The following is a description of a gene set: studied in species Homo sapiens Any process that modulates the frequency, rate, or extent of heterotypic cell-cell adhesion. Human Gene Set: GOBP_REGULATION_OF_HETEROTYPIC_CELL_CELL_ADHESION, and this is the list of marker genes: MAP2K5, TNF, IL1B, AGER, CEACAM6, APOA1, GCNT2, LCK, MIR221, FGG, BMP7, WNK1, MBP, SKAP1, ADIPOQ, FLOT1, MYADM, FGA, IL10 (interleukin 10), FGB, IL1RN, MAPK7 (NCBI Gene Id 5598), CD44, KLF4, FLOT2